The following is a description of a gene set: MicroRNA-155 (miR-155) is upregulated in primary effector CD8 T cells but is expressed at low amounts in naïve cells. Anti-viral CD8 T cell responses and viral clearance were impaired in miR-155 deficient (bic-/-) mice, and this defect was intrinsic to CD8 T cells, as adoptively transferred bic-/- CD8 T cells generated greatly reduced primary and memory responses during infection. To understand the mechanism by which miR-155 regulates CD8 T cell activation, we analyzed the gene expression profiles of naive and in vitro activated wild-type and bic-/- CD8 T cells. studied in species Homo sapiens Human Gene Set: GSE44649_NAIVE_VS_ACTIVATED_CD8_TCELL_DN Genes down-regulated in CD8 T cells: resting versus activated. from publication Gracias DT, Stelekati E, Hope JL, Boesteanu AC, Doering TA, Norton J, Mueller YM, Fraietta JA, Wherry EJ, Turner M, Katsikis PD (PMID 23603793), and this is the list of marker genes: ATP5IF1, VSIR, HECA, NUP37, MCCC2, CEP20, COQ3, LDB3, MIS18A, DAPK1 (death associated protein kinase 1), C12orf57, PER3, ATAD2, RNF168, TRPM2, B3GALNT2, NTAQ1, MAP4K2, ZNF569, PRADC1, RAB33B, DEPDC7, KLF10, PIN4, RNLS, PCBD2, TUBE1, CFAP97, OLIG2 (NCBI Gene Id 10215), TFDP1, UBR1, GAS6, R3HDM1, FNDC5, EPCAM, CKS1B, HCFC2, RNFT1, AMZ2, TM9SF3, ENGASE, OSGEPL1, NFS1, PCCB, HPS4, MARVELD2, METTL21A, DZIP3, FAM120A, CD9, MRPS25, CDC14A, ELP1, AHRR, PRKAG2, GLO1, BLM, PURA, DCUN1D4, LIN54 (lin-54 DREAM MuvB core complex component), CAAP1, CTNS, TVP23B, UQCR11, NFYB, NUS1, CHML, LRR1, EPM2AIP1, MBOAT1, FIGNL1, CYP4V2, PBXIP1, DHODH, TYW1, RWDD3, CENPK, IRF2BPL, DCAF12, FNTA, RCOR1, CLIP1, PRKCI, MBTPS2, CERT1, AMOT (NCBI Gene Id 23340), NAA50, SKP2, TMEM98, GEMIN6, IGIP, MNS1, PSMA8, TENT4B, RPP14, ARHGAP5, RWDD4, TERF1, KIFBP, HAUS4, SHPRH, RIDA, RNF144B, UBE2T, TIMM21, PPP3CA, TRAPPC13, ECHDC1, PTEN, ZNF141, TMEM135, SSX2IP, TEX2, ABRAXAS1, SELENOT, SPC24, ARFGEF2, KLHDC10, AAMDC, IPO11, USP6NL, TBL1XR1, RRM1, TP53INP1, TTC13, NDUFA13, DSCC1, MIB1, GNG2, PSMC3IP (NCBI Gene Id 51769), FIRRM, MZT1, TMEM109, INSR, HDAC2, MCEE, MBLAC1, IPO7, NDUFB8, EML4, PTGR2, ALDOC, ANP32E, MYG1, TXNDC12, CENPO, SHQ1, TIRAP, CCNE2, ACTL6A, MRPL50, ADGRL3, NPAT, FLI1, SLC25A26, SLC19A2, LEPROT, EFCAB7, SREK1IP1, ENTPD5, KBTBD8, MSL2, STIM2, ALG10, DCUN1D1, SCP2, PANK1, NUDCD1, BORA, TMEM241, AP1S3, CDPF1, POLA1, INPP1, KCTD16, DIAPH2, CDKN2AIPNL, SRSF1 (NCBI Gene Id 650453), BEX3, KDM7A, MCPH1, PHC3, ARHGAP21, HAUS6, MYOM1, COX7A2L, CLTRN (NCBI Gene Id 57393), IMMP1L, RAB38, NUP210, PIGF, NTMT2, MBNL3, IMPA2, MPHOSPH6, NEURL1B, NSL1, QDPR, CDC25C, C18orf54